Given this list of marker genes Fgf16, Fgf18, Fgf20, Fgf5, Fgf8, Fgf2, Fgf7, Fgf1, Fgf17, Fgf3, Fgf9, Fgf22, Fgf4, Fgf23, Plcg1, Fgf10, Fgf6, here is a description of the gene set: Phospholipase C-mediated cascade; FGFR2 studied in species Mus musculus Mouse Gene Set: REACTOME_PHOSPHOLIPASE_C_MEDIATED_CASCADE_FGFR2